Given this list of marker genes PAX2, ARHGAP24, NUP107, APOL1, ANTXR1, EFEMP1, HLA-DPB1, GPR101, KCTD1, COL5A1, FBXO11, NUP85, PTPN22, NUP160, GAPVD1, MED12L, TRPC6, ZNHIT3, GTF2I, FKBP6, POU4F1, COL5A2, NPHS2, RIN2, PIK3CD, INF2 (NCBI Gene Id 84800), ANLN, RBMX, CAMTA1, KPTN, ACTN4, SERPING1, SNX14, GTF2IRD1, BUD23, COL4A3, AIP, GTF2IRD2, SLC29A3, HLA-DPA1, NPHS1 (NPHS1 adhesion molecule, nephrin), CD2AP, EMP2, IGSF3, CCBE1, TBL2, POMP, PEX5, NUP37, COL1A1, CLIP2, PEX2, SLC35C1, SOX18, RFC2, CRB2, ANKFY1, NUP133, MAGI2, LIMK1, ACTB, SPTBN1, PIEZO1 (piezo type mechanosensitive ion channel component 1 (Er blood group)), DNAJC30, ARHGDIA, LYN, EIF4H, KNSTRN, COQ8B, TNFRSF1A, GNPTAB, NUP205, ACTG1, MYD88, ELN, CTLA4, VPS37D, DAAM2, PSMB4, DHX30, WT1, PLCE1, MYO1E, LTBP4, ADAMTS2, GSN, FRMD4A, TGFBI, EPHB4, SHANK3, NUP93, SUMF1, PTPRO, STX1A, METTL27, PSPH, PRTN3, XPNPEP2, TMEM270, FOXG1, TBC1D8B, NCF1, CDH11, KAT6A, BAZ1B, here is a description of the gene set: Edema affecting the region situated around the orbit of the eye. Human Gene Set: HP_PERIORBITAL_EDEMA Periorbital edema studied in species Homo sapiens